The following is a description of a gene set: from publication Sesto A, Navarro M, Burslem F, Jorcano JL (PMID 11867738) Cluster 5: genes changed in primary keratinocytes by UVB irradiation. Human Gene Set: SESTO_RESPONSE_TO_UV_C5 studied in species Homo sapiens UV radiation is the most important environmental skin aggressor, causing cancer and other problems. This paper reports the use of oligonucleotide microarray technology to determine changes in gene expression in human keratinocytes after UVB treatment. Examination of the effects of different doses at different times after irradiation gave a global picture of the keratinocyte response to this type of insult. Five hundred thirty-nine regulated transcripts were found and organized into nine different clusters depending on behavior patterns. Classification of these genes into 23 functional categories revealed that several biological processes are globally affected by UVB. In addition to confirming a majority up-regulation of the transcripts related to the UV-specific inflammatory and stress responses, significant increases were seen in the expression of genes involved in basal transcription, splicing, and translation as well as in the proteasome-mediated degradation category. On the other hand, those transcripts belonging to the metabolism and adhesion categories were strongly downregulated. These results demonstrate the complexity of the transcriptional profile of the UVB response, describe several cellular processes previously not known to be affected by UV irradiation, and serve as a basis for the global characterization of UV-regulated genes and pathways., and this is the list of marker genes: EIF2AK2, MYC, GTF3C2, TIAM1, LDLR, ABCC1, PKN2, JAG1, CKAP5 (cytoskeleton associated protein 5), RCOR1, TGFBR2, YES1, SLK, EPS15, ITGB4, NCOR2, METAP1, TLK1, MCL1, PPP4R1, CLINT1, RASA1 (NCBI Gene Id 5921), MME, ABLIM1, GSK3B, PAFAH1B1, RAB2A, STAT1, WWP1, ZNF148, FAM120A, SDC4, CLIP1, HMGA2, PBX3, IQGAP1, RBBP8, SREBF1, PUM1, NFE2L2, HES1, PIK3R4, SHB, CBFB, EXT1, VGLL4